The following is a description of a gene set: species: Mus musculus Reactome Pathway: Trafficking of myristoylated proteins to the cilium electronically inferred by orthology from the curated human pathway part of: Cargo trafficking to the periciliary membrane This event has been computationally inferred from an event that has been demonstrated in another species.<p>The inference is based on the homology mapping from PANTHER. Briefly, reactions for which all involved PhysicalEntities (in input, output and catalyst) have a mapped orthologue/paralogue (for complexes at least 75% of components must have a mapping) are inferred to the other species., and this is the list of marker genes: Rp2, Nphp3, Arl3